Given this list of marker genes Mir129-2, Aste1, Lonp2, Uqcrc2, Asxl1, 4930451E10Rik, Kcnt2, Gpr107, Trbv30, Lum (lumican), Dnajc8, Tjp2, Slc25a38, Gm25856, Hvcn1, Anxa7 (NCBI Gene Id 11750), Recql, Uba52, Wfs1, Prickle4, Gm12333, Or5m5, Capza1, Zcchc14, Tm4sf5, Ugdh, Ccnt2, Fam241b, Nadk2, Gm42161, Lrrc4c, Vti1a, Pja1, Atp5mj, Trp53i13 (NCBI Gene Id 67875), Gm26176, Usb1, Gm12393, Nfkbiz, Zfp212, Gltpd2, Gm15039, Mir217, Heg1, Park7, Pold3, 1700020L13Rik, St3gal6, 8030423F21Rik, Lypd10, Sptb, Mpped2 (metallophosphoesterase domain containing 2), Il33, Arrdc3, Plin1, Pam, Uchl5, Atpaf1, Papola, Ecpas, Zfp599, 5730409E04Rik, Map6, Gm42918, Wdr12, Gm12401, Wipf1, Atg2a, Grip1, Mir568, Hoxa3, Nhlrc2, Nmi, Mir215, Ankib1, Jak1, Usp51, Ino80d, Cep63, Snhg14, Smpd1, Ces1d, Acad9, Ubxn1, Syne2, Cadm1, Gm26795, Thap1, Smad7, Znrf1, Chadl, Triap1, Cit, Taco1, 1500015A07Rik, Uqcrh-ps2, Cfh, Aspscr1, Fzd10os, Fbxo21, Plin2, Trp53cor1, 4933415A04Rik, Gm14175, BB218582, Tsg101, Tkt, Arl1, Pax2, Rian, Fam193b, Smagp, Otud4, Ralgps2, Pkd2l1, Gipc2, Rpl30-ps6, Vps72, Agtrap, Fry, Grm1, Tpd52, Ccdc9, Gm15780, Cers2, Zfat, Gtf2i, Rab43, Swsap1, Rpl10-ps2, Bcl2l13, Ephb6, Rassf1, Zfp975, Gm26490, Ckap2, Dnajc21, Rrp7a (ribosomal RNA processing 7 homolog A), Lsm10, Atxn1l, Smim8, Adal, Gm8969, Ebp, Cirbp, Zfp715, Anxa3, Xrcc4, Cklf, Alas1, Gm23706, Hhip, Ccdc74a, Src, Fbrsl1, E130114P18Rik, Plce1, Tagln2, Suv39h1, Gm13387, Ube2d2b, Gm5255, Heatr3, Dpep3, Zfp809 (zinc finger protein 809), Mir19a, Mfn1, Rapgefl1, Fbxl22, Sipa1, Fmnl3, Cdk2ap1, Pcmt1, Sntb2, Mrps10, Pms1, Gm15411, Mettl8, Rad50, Tnc, Drosha, Jup, Tmem42, Ppp1r15a, Rnf6, Gm23090, Zfp157, Opcml, Dhtkd1, Meis1, Niban3, Ric8b, Tmcc1, Altre, Synrg, Lancl1, Ehd4, Pomp, Tex14, Son, Smarcb1, Fmo1, Nrm, Rtel1, Pole3, Tbcd, Klk8, Mkln1, Larp4, 2310034O05Rik, Zfp36l1, Cyb5r1, Bmp5, Pde4dip, Rtl5, Lag3, Rgs16 (regulator of G-protein signaling 16), Dcbld2, 5730480H06Rik, Rrm2b, Dnajc11, Cep164, Or8g19, Slc36a1os, Kdm1a, Ly6g, Adgrl1, Mir5709, Atf7ip, Hint1, Mvd, A930001C03Rik, Gli2, Bnc1, Mms19, Prss43, Cltc, Slc4a1ap, Arf5, Maf, Mxd4, Gm13785, Gripap1, Mdm4-ps, Mfsd11, Or11a3-ps1, Gfer, Frat1, Phb1, Gm7285, Gadd45b, Pif1, Aurka, Fbxo28, 1700066B17Rik, Zfp438, Wdr75, Gm22270, Elp5, B4galt7, Gm12189, Mtus2, Pcmtd2, Treml4, Atf6, Pask, Gm25552, Gm25482, Gm13207, Rps6ka1 (ribosomal protein S6 kinase polypeptide 1), Nmnat2, Camk1g, Cpsf6, Map3k8, Vcan, Tpt1, Fanca, Gm10657, Rpsa-ps5, 2610206C17Rik, Rhot1 (ras homolog family member T1), Fam114a2, Ctdspl2, Git2, Zfp276, Zfp82, Uts2r, Paqr8, Ccndbp1, Ncapg2, Ptrh2, Snora81, Uimc1 (NCBI Gene Id 77298), Ager, App, 4930512H18Rik, Tet2, Gemin2, Zc3hc1, Rwdd4a, Celf1, Sirpd, Pccb, Phactr4, Sptbn2 (spectrin beta, non-erythrocytic 2), Gm10157, Gm22681, Dclre1a, Foxc1, Arpc5l, Itpa, Ccdc170 (coiled-coil domain containing 170), Eif4a2, Fgfr1, Ppip5k1, A830031A19Rik, Lgmn, Cystm1, Bcl11b, Maged1 (NCBI Gene Id 94275), Srsf11, Zfp790, Gm26871, Dhx38, Mir7035, Itga9, Gfm2, 2500004C02Rik, Npr3, Ncam2 (NCBI Gene Id 18257), Cbfb, Gm13110, Dot1l, Gm8213, Emc3, Bcas3, Kcnt1, Actr8, Or1e25, C330002G04Rik, Cldn22, Elavl4, Zbtb34, Adarb1, Gm25526, Rcan2, Myo18a, Ttll9, Atrx, Raf1, Tlcd3b, Hspa4, Tgif1, Sqor, Gm12125, Borcs5, Rps6ka3, Atp6v0d1, 1700003F12Rik, Nhlrc3, Gm25917, Gm16463, Gm26447, Hspd1 (NCBI Gene Id 15510), Garnl3, Glis3, Arhgef15, Gm11454, 2210417A02Rik, Prpf38b, Arhgef7, Sh3kbp1, Lifr, Hoxc11, Gins2, Tprg1l, Usp3, Gm19705 (predicted gene, 19705), Rbm25, Tbx3os1, Slc9a8, Zfx, 4930556N13Rik, Rtp3, Asic3, Gm15708, Arl3, Kdm5c, Scmh1, Plbd2, 4931406C07Rik, Slc8a1, BC043934, Dpp6, Tmem266, Gna11, Pi4ka, Skida1, Jph1, Arpp21, Zfp143, Ncoa4, Tomm34, Asb3, Isca1, Rere, Zbtb44, Nhsl2, Armh3, Serpine2, Ncaph, Ddb2, Tulp1, Diaph1, Crem, Spp1, Il1rapl2, Timm13, Sla, Mas1 (NCBI Gene Id 17171), Slc25a13, Appl1, Gm25224, Zcchc10, 4930533L02Rik, Map1lc3b, Gpr68, Btbd19, D630008O14Rik, Eif3k, Gpr45, 9330162B11Rik, Fam98c, Copg2, Adam32, AW047730, Aim2, Zfp319, Mrps31, Gm43772, Ppfibp2, Gm23182, 3110045C21Rik, C2cd4a, Tnfaip3, Pom121, Ube2f, Mirlet7g, Gigyf2, Pip4k2c, Emx2, Iho1, Smpd2 (NCBI Gene Id 20598), Gm4321, Acbd6, a, Xab2, Cox11, Nsun5, Ncor1, Ift140, Srebf1, Farsb, Hmgb1-rs16, Pde9a, Atrip, Gm26885, Gm11346, Gm22881, Wnk1, Gm10655, Tmem18, Apobec1, Ywhah, Cln3, Gm20033, Gm14098, Gm25608, Gm15651, Tmem134, Hnrnpu, Pdgfd, Gm17076, Catsper2, Chl1, 2310016D23Rik, Mgme1, Mta3, Magohb, Gm6462 (NCBI Gene Id 638892), Gm2990, Gm23769, Gm24068, Gm17815, Nr5a2, Plek, Rpl36-ps1, Plekhs1, Sspn, Sec23a, Usp1, Sulf1, Gm4832, Luc7l2, Gm20404, R3hdm2 (NCBI Gene Id 71750), Gm22935, Ipo11, Gm42799, Ankrd10, Ywhag, Gm12654, Cd164, Mepce, Onecut2, C1galt1, Ushbp1, Gm6985, Rpl6, Gm14125, Scd4, Sfmbt2, Gm4784, Dlk1, Ipo8, Pdlim1, Ccr4, Defb40, Gm23605, Gm12950, Lrriq1, Pde4c, Cpd, Slc43a1, Trpm1, Spice1, Bcas2, Gm11379, Ccdc63, Cd9, Mcm3ap, Gm15032, 1700120B22Rik, Rsu1, Phf24, Vav1, Csrnp3, Fuca1, Gm23502, Capn11, Cox7a1, Ifitm10, Tyw1, Cngb3, Gm12339, 2510002D24Rik, Zfp661, Mir376a, Rhoh, Best4-ps, Adra1a, Safb2 (NCBI Gene Id 433127), Pdcd6ip, Tfr2, Atp5f1a, Gm13689, Acvr1, Tanc2, Psmd7, 9530068E07Rik, Hdac4, Prkag1, Ifrd1, Txnl4b, Irf8, Edrf1 (erythroid differentiation regulatory factor 1), Ccdc185, Rsl24d1, Trap1, D830025C05Rik, Thoc2, Uba7, Ercc6, Gm7774, Nfat5 (NCBI Gene Id 54446), Agap3, Mob3a, Gm15047, Mir770, Cbr4, Psmd4, Mir7664, Actb, Pigb, Tmem248, Mir7673, Fgd4, Hormad2 (HORMA domain containing 2), Tspan8, Krtap20-2, Rnf169, Gm973, Acad11, Zdhhc6, Myo15a, Slc36a1 (NCBI Gene Id 76010), Gm12655, Slurp2 (secreted Ly6/Plaur domain containing 2), Cspp1, Hsd17b7, Fancd2, Zc3h12b, Taf1c, Rassf3, Sirt7, Pou2f1, Mir7668, Mindy3, Fbxl3, Hsf3, Ifng, Abca16, Snhg12, Nckap1, Ubqln4, Gm11691, Gm18254, Znfx1, Gckr, Notch4, Gm15927, Ubald1, Mir18, Rnf113a1, As3mt, Car7, Surf6, Mia2, Ttc13, Cfap69, Slc6a4, Gm23123, Mef2c, Syne4, Serpinb11 (serine (or cysteine) peptidase inhibitor, clade B (ovalbumin), member 11), Gm8883, Tfap4, Dennd2a, Arhgap27os1, Itpr2, Sfmbt1, Tmeff2, Ift81, Uba2, Rfc2, Sergef, Zmym1, 4930515G01Rik, Ascc1, Bcas1, A930018P22Rik, Gm23202, 1810053B23Rik, Rph3a (rabphilin 3A), Acbd4, Mto1, Gm29332, Hmgcr, Cdc42bpa, Mir6385, Fig4, Gm26247, Islr, Flt1, Limk2, Cyp2c70, Smim14, Shprh, Hoxa11os, Recql5, Mpi, 0610043K17Rik, 4930505A04Rik (RIKEN cDNA 4930505A04 gene), Srpk1, Fbxo11 (NCBI Gene Id 98072), Helz, Rps27a-ps3, Hs6st1 (NCBI Gene Id 50785), Prim2, B130024G19Rik, Rffl, Speg, Mindy1, Rell1, Hsd3b7, Gm23382, Nat10 (NCBI Gene Id 98956), Mrpl4, Map2k4, Taf6l, Cenpk, Med21 (NCBI Gene Id 97336), Atxn2, Gm8022, Efna3, Phactr1 (phosphatase and actin regulator 1, NCBI Gene Id 78746), Mid1, Tnfrsf1a, Rsph9, Neto1, 1700052H01Rik, Ufsp2, Gm13291, Stxbp3, Dnaaf9, Slc38a8, Tvp23b, Cygb, Plekha5, Smg5, Arhgap18, Pdia3, Spata6l, Setd7, Lrrc2, Arhgap12, Gm28401, Plekha6, Map4, Pgap2, Gm7891, Zfa-ps, Thoc2l, Abcb9, Gm11531, Taf4, Gtf2h2, Shc1, Synpo2l, Gm12501, Tor1aip1, Evl (NCBI Gene Id 14026), Tmem163, Clcn7, Arih2, Gm9887, Kcnk6, Map2k1 (mitogen-activated protein kinase kinase 1), Grin3b, Tmem131l, Ctnna3, Sun1, Gm15583, Ptprc, P2rx3, Magea2, Slc7a11, Mdfic2, Pipox, Thoc3, Dlgap5, Lbr, Rngtt, Mirg, Gm12610, Rfx7, Nrdc, Mir3092, Sertad2, Steap3, Rhod, Trim6, Nepn, Mir103-2, Rbm5, Lgals4, Vamp1, Lrig2, E2f2, 4930402F06Rik, Ube2e1, Tlr7, Palld, Ralgapa2, Gm5764, Pde4d, Atp7a, Gm13213, Zfp748, Tcp11 (t-complex protein 11), Lhfpl6, Ank, Caps2, Hsp90ab1, Uba5, Exosc1, Commd3, Stx3 (NCBI Gene Id 20908), Gmcl1, D030068K23Rik, Dbn1, Uvrag, Clec2e, Nudt1, Arl2bp, Baz1b, Stox2, Yipf1, Rex1bd, Matn3, Snph, Msh3, Plaa, Csde1, Gm15328 (predicted gene 15328), B3gnt7, Gm22422, Hbp1 (NCBI Gene Id 77235), Golga2, Mdc1, Platr6, B230208H11Rik, Il31, Abca4, Lztr1, Ilf2, Pnkp, Ddx23, Zfp507, Cenpi, Ephx3, Sass6, Klhl22, Tsga13, Gm16016, Gm22981, Tpk1, Acat1, Gm11802, Gm14534, Orc4, Gm16185, Tspyl2, Gm25102, Or6n1, Pgp, Hhat, Mir20a, Eif1ad, Gm10069, Acap1, S100a4, Mir7075 (microRNA 7075), G3bp2, Mgst3, Ddx60, Fbxl17, Tmem102, Nup160, Gm22122, Gstt2, Mycbp, Arhgap39 (Rho GTPase activating protein 39), Zp1, Hspe1, Gm13522, Rrp8, Gm6096, Rpl5, Cc2d2a, Gm4342, Gm11775, Snrnp25, Gm18901, Pkp4, Msrb3, Slc38a6, Tmco2, 2900079G21Rik, Gm10532, Dnttip2, Gdi2, Gm2800, Mcf2l, Rpl21, Hyls1, Milr1, Nme4, Gal3st1 (NCBI Gene Id 54452), Gm37885, Sp1, Lrp2bp, Ptp4a1, Uhrf1, Rbbp6, Zfp217, Elk4, Mecomos, B4galt6, Fam107b, Gm14082, Gm24592, Strada, Crot, Evc2, Fkbp8, 2410002F23Rik, Wdr43, Immp1l, Anapc15, Lyz1, Ccl7, Amz1, Cngb1, Psmd14, Gm27219, Gm22972, Gm26705, Echs1, Aknad1, Brix1, Ccdc116, Ngdn, Inpp5k, Bcar3, Neil3, Gm12653, Dis3l, Gm12271, Snta1, Cfap74, Gm27811, Brms1l, Slc25a19, Nrbp1, Slc12a6, Ruvbl1, Ints2, Ccdc110, Foxd2, Gata3, Nvl (NCBI Gene Id 67459), Ctnnal1, Bckdhb, Gm13180, Foxl2os, Sos2, Gm11655 (predicted gene 11655), Gm12828, Zfp946, Ptprr, Morf4l2, Elp1, Rbm47, Chd2, Parp14, Septin9, Cd164l2, Cse1l, Mb, Cplx4, Sec16a, Reps1, Mlxip, Tcp1, Gm12740, 1600010M07Rik, Ocrl, Zdhhc21, Rabl6, Aars1, Galnt1, Dlat, Hapstr1, Pik3cd, Fam83c, Eml6, Rpn2, Spcs1, Hnrnpr, Mgat1, Mrpl50, Ergic1 (endoplasmic reticulum-golgi intermediate compartment 1), Tmem161a, Kat14, Ppme1, Gm22973, Cryl1, Meox1 (mesenchyme homeobox 1), Eid2, Ogt, Wdfy3, Gm25848, Zfp318, Spin1, Vpreb1a, Nabp1, Atp8b4, Pole2, Best2, Nrbf2, Nmnat3 (nicotinamide nucleotide adenylyltransferase 3), Gm10531, Eif5al3-ps, Chrna10, Mettl4-ps1, Gm12980, Syt12, F830112A20Rik, Bag5, Fam169b, Klhdc2, Gm13842, Qtrt2, Rnaseh2a, Faiml, Crnde, Prss54, Spink10, Zfp532, Ak9, Papss2, Arf4, Gm5424, Gm12313, Ezh1, Gm9443, Adam17, Gulo, Gm43526, Cpsf1, Gm12091, Ankrd17, Mical2 (NCBI Gene Id 70877), Gm12109, Slc2a9, Zfp568, 1700023H06Rik (NCBI Gene Id 69442), Kcnip2, Nfe2, Tm2d2, A930019D19Rik, Dipk1b, Manba, Usp4, 9430007M09Rik, Zbtb8a, Rtl6, Zic1, Fxn, Mtfr1, Ccdc14, Eri3, Ift80, Slc25a51, Mgst2, Fhip2b, Serpinb10 (NCBI Gene Id 98753), Dohh, Oaz2-ps, Gm23483, C5ar2, Pak4, Nuak2, Erbb4, 2010016I18Rik, Tor1aip2, Hcfc1r1, Serpinb6e, Thbs3, Gm10073, Mast1, Rnf157, Slfn5, Setd2, Kcnh8, Luc7l3, Lrrc37, Gm25973, Rogdi, Parl, Pid1, Tango2, Tmed2, Gnpat, Hook3, Mir100hg, St14, Spred2, Runx1, Gm29707, Mir1191, Slc12a3, C2cd5, Pitpnc1, Itgbl1, Vps8, Cilk1, Rab3gap1, Pi4k2b, 5830487J09Rik, Rcc1, Pde4b, Mir19b-1, Flvcr1, Cdc42se2, 4930412F09Rik, Wdr5, Rasa4, Zpld1, Ttc33, Rtf2, Atg16l1, Gm26684, Btrc, Shmt1, Zfp27, Fxr2, Gm9134, Necap1, Bola2, Mir218-1, Dgcr8, Ndfip2, Setd1a, Gm26253, Samd10, Pou5f1, A530041M06Rik, Ndufa12-ps, Eva1c, Actc1, Hspa9, Sel1l3 (NCBI Gene Id 69691), Gm10309, Nr2c2, Hmg20b, Dkkl1, Map4k4 (NCBI Gene Id 98646), Sorcs2 (sortilin-related VPS10 domain containing receptor 2), Phf21a (PHD finger protein 21A), Snora17, Syt3, Rigi, Gm23054, Amhr2, Psma3, Tigd4, Nav2, Or2r2, Nr4a3 (nuclear receptor subfamily 4, group A, member 3), Fat2, 1110028F18Rik, A230083N12Rik, Izumo4 (NCBI Gene Id 71564), Tm9sf4, Msmo1, Synpo2, Capns1, Ech1, Arhgap15, Csdc2, Cyp4f15, Rnpep, Pigm, Ly6g6f, Rad54l, Hbq1b, Col10a1 (collagen, type X, alpha 1), Rcbtb1, 4930568G15Rik, Smpd5, Xpa, Snhg7os, Sned1, Gm12886, Dnah2, A2ml1, Ess2, Sardh, Smco4, Gm25091, Xpo4, Ighg1, Tmem33, Ece1, Mxd3, Cops8, Cntnap5c, Mfap1b, Taf1d, Gm11149, P2rx7, Selenon, Smg6 (NCBI Gene Id 216951), Septin12, Ube2d2a, Ebna1bp2, Spmip6, Eno4, 0610031O16Rik, Nfxl1, Alg11, Kcnj16, Ift122, Cep85, Gm12608, Cep44, Anp32e, Entpd1, Prkrip1 (Prkr interacting protein 1 (IL11 inducible)), Tbc1d14, Sbno1, 5830432E09Rik (NCBI Gene Id 67765), Mir7675, Slx4, Rassf9, Entpd8, Psma7, Pan3, Nipbl, Capn10, Syt8, Bcl6, A630072M18Rik, Adipor2, Vipr1, Ing3, Wsb1 (NCBI Gene Id 78889), Gm12571, Aff1, Fam76a, Rsbn1l, Ankrd40, Cp, Gm20443, Ext2, Tnks2, Fbxo31, Zbtb20, Tram1, Virma, Sez6, AI115009, Slc25a36, Rtn4, F2, Vgll4, Gm29994, Pdia4, Enah, Gm3830, Shroom3, Hexim2, Trim34a, Gm20005, Abo, Ttc39c, Foxp1, Gnl3, Lrrc8d (NCBI Gene Id 75118), Xpnpep1, Uqcrc1, Fra10ac1, Art1, Herc1 (NCBI Gene Id 78507), Gm6491, Fbxl20, Rgs9, Psph, Slc2a3, Ppp1r8 (NCBI Gene Id 230788), Rtraf, Ccdc47, Gpr157, Gm20706, Ribc2, Gm7831, G6pc3, Adam10, Tnik, Prkab1, Usp21, Tmem242, Arhgap28, Epdr1, Aen, Creb3l3, Fam90a1b, Tbc1d8b, Phf3, Rab11fip5, Babam2, Gm12848, Lhfpl2, Redic1, Zfp866, Slco1c1, Impdh1, Smc1b, Tlr2, Pierce2, Tcf4, Top3b, Gm15413, Plekhg1, Skic3, Snx1, H4c6, Tfrc, Gm11444, Togaram2, Vps39, Nrde2, Atp5f1b, Dpy19l1, Foxm1, Cars2, 9430015G10Rik, Tomm20, Shroom1, Gm16351, Eif3l, Gm24145, A830035A12Rik, Usp53, Cyp4a28-ps, Sapcd2, Glrx2, Mdk, D030056L22Rik, Gm28836, Taok2, Chchd10, AA986860, Rab34, St7, H2bw2, Gm24461, Mrpl21, Tbrg4, Pik3ap1, Sf3b1, Gm5532, Mir411, Gm25137, Lrrc23, Cul5, Gm24978 (predicted gene, 24978), Gjb3, Zc2hc1a, Faddos, Map2k3, Pitpnm2, Jakmip1, BC065397, Jade1, Ctsh, Rad51ap2 (NCBI Gene Id 633407), Psmc1, Nudt5, Kyat1, 2900092N22Rik, Rnf43, 1700017B05Rik, Acot11, Gm15197, Rad54l2, Oaz3, Trmt9b (NCBI Gene Id 319582), Crls1, Nell1, Abcg5, Rbm20, Fpgs, Hoxa11, Gm24780, Bex6, Gm11191, Rcor3, Mir6417, Mbtps2, Phf20, Gm4285, Gm15222, Gm8805, Agfg2, Abcf3, Clec4a1, Gm7181, Adcy7 (adenylate cyclase 7), Dse (NCBI Gene Id 212898), Sting1, Mir6381, Atp6v0a1, Fam162b, Cracr2b, Azin1, Six4, Nbdy, Mospd3, Gm5258, Pigx, Pfkfb1, Ncmap, Zfp512b, Tnfaip6, 1700036A12Rik, Gm24616, Adh1, Drg1, Gm14987, Mir3618, Slit2, Gm23479, Klf8, Fus, Klhl18, St6gal1, Sptan1, Aifm1, Vwa3b, Rp31-ps19, Xylb, Smc4, Pop1, Zbtb43, Cwh43, Gm12650, Gm16276, Mllt10, Mta2, Ppp2r5c, Alkbh1, Coq10b, St13, Cdh13, Tgoln1, Lingo4, Rptor, Rnf125, Asl, Dnmt3a, Mtmr3, Myh13, Plcxd2, Zfp612, Gm11665 (predicted gene 11665, NCBI Gene Id 100415912), Gm10244, Mroh7 (maestro heat-like repeat family member 7), Caap1 (caspase activity and apoptosis inhibitor 1), Fnbp4, Sycp2l, Ubap1, Gnai2, Ttyh2, Sf3a3, Bloodlinc, Ipo9, Mthfsd, Apom, Tns1, Mir99ahg, Tdrd9, Ppp1r10, Slc1a1, Kctd3, Mir3085, Ptp4a2, Ankdd1a, Tdrp, Fbxo42, Fzd10, Defb23, Satb1, Galnt3, Atp1b3, Spag5, Zfp653, Olig3 (NCBI Gene Id 94222), Mtf2, Nicn1, Cnga3, Phldb2, Gm6366, Paics, Mrm2, Il23a, Mettl13, En1, Kcnu1, Utp25, Tjp1, A530064N14Rik, Cd101, Stk36, Tpm3, Sybu, Hopxos, Klhl31, Clstn1, 4930526A20Rik, Oas2, 4933430I17Rik, Tac4, Shbg, Xpnpep3, Dync1h1, B630019A10Rik, Pex1, Ambra1, Nudt12, Pde7b, Hspa8, Mir654, Gm13347, Tmem45a, Gm28874, Ccdc198, Tmem200a, Gm26044, Gm12936 (NCBI Gene Id 675326), Nasp (nuclear autoantigenic sperm protein (histone-binding)), Atcay, Ttc3, Gaa, Ralbp1 (NCBI Gene Id 268968), Dph2, Stk11ip, Gm5619, Metap2, Sec24c, Yipf6, Usf2, Snora61, Setdb2, Gm12977, Setx, Nabp2, Gm7928, Bmt2, Fgd5, Ube2z, Mir1306, Mrpl22, Raver2, Aip, Mir763, Defb42, Trip12, 4933408N05Rik, Pgpep1l (pyroglutamyl-peptidase I-like), Adamts6, Nrgn, Rpl21-ps9, Or4c35, Phex, Igf1r, Pcdhga8, Gm20544, Gm15066, Kcnv2, Gm4877, Mdn1, Strap, Gm11452, Gm5976, Vps4a, Ppp4r4, Ino80dos, Gm14111, Mrpl28 (NCBI Gene Id 68611), Acaa1b, Crcp, 1700094J05Rik, Phyh, Ttc29, Tle3, Gm19224, Mir17hg (NCBI Gene Id 75957), Gm24793, Med18, Rbpms2, Gm25184, Atp8b3, Gfm1 (G elongation factor, mitochondrial 1), Kdm5a, Misp, Cyb5r3, Inpp5b, Gm13755, Ube2r2, 2310009B15Rik, Cdkn1a, Gm5248, Rps2-ps11, Gm25609, Or10ad1, Rsrc1, AU016765, Rufy2, Arl6ip5, Ipo13, Atp5f1d, Slc25a14, Mat2b, Mir7238, Gamt, Gm16089, Atp6v0b, Mroh1, Gins1, Gm14101, Thoc1, Gm5787, Stra6 (stimulated by retinoic acid gene 6), Zfp7, Tceanc2, Gm24878, Kash5, Gm16599, Nrl, Eef2k, Pstpip1, Gm30835, D830032E09Rik, Bltp2, Gm6209, Radx, Uts2, Mecom, Gm7094, Lat2, 4933434E20Rik, Gm2245, Pknox1, Ganc, Fam83e, Smg7, Mir376c, Shisa5, Mzf1, Lyg1, Mir3099, Rai1, Lyzl6 (lysozyme-like 6), Sinhcaf, Mgat5, Gzmm, Marchf2, Gm10268, Nop58, S1pr4, Fancl, Zmiz2, Nemp2, Tra2b, Gm31266, Eps15, C530043K16Rik, Magi2, Casp8, Ankrd1, Ms4a4c, Ptges3, Pigc, Pik3ip1, Kif22, Lrrc75aos1, Nectin3, 4932412D23Rik, 4930509H03Rik, Snora16a, Ica1l, Plekhm3, Lamp2, Lratd1, Ccdc88a, Tmem219, Zfand4, Gm16283, Pcdhgc5, Tenm4, Mir376b, Aldoa, Naprt, Srsf1, Yeats2, Mir7669, Esr2, Gm25968, Babam1, Tmcc2, Mylpf, Mir17, Adgrb3, Mir6944, Gm15881, Fnta, 2010109A12Rik, Uggt1, Trpv2, Pkdcc, 1700001O22Rik, Poc1a, Lst1, Phip, Ubtd2, Pigh, Runx2, Slc41a2, Slc3a2, Nkain1 (NCBI Gene Id 72746), Man2c1, Dhx33, Rpl9-ps4 (NCBI Gene Id 100042832), Txndc2, Arhgap23, Tpd52l2, Rragc, Pou6f1, Brd1, Snora44, Slc7a7, 1810044D09Rik, Tbx15, Gm14227, Uevld (NCBI Gene Id 71499), Slc27a5, Snf8, Ninj2, Abcc3, Spmip3, Morc4, Spats1, Slc35a3, Kctd5, A430005L14Rik, Pspn, Gm25788, Desi1, Zfp280d, Gm26049, Rhbdd2, Gm15610, Or4k52, Cldn12, Mir3475, Platr22, Dars2, Arhgap4, 5031434O11Rik, Lypd6b, Syngap1, Irf3, Ankrd60, Gm9506, C030013C21Rik, Plcl2, Slc18a3, Gm28729 (NCBI Gene Id 102635744), Zhx3, 9230104M06Rik, Nrg4, Camk1, Zpbp2, E2f1, Esrp1, Fgf9, Zwilch, H2-M5, Fkbp4, Echdc2, Erg, Selplg, Adat1, Gm26070, Gm24665, Ankrd24, Ubap2l, Rab27a, Gm12924, Dhx9, Fau-ps2, Cnbd2, Gpr35, Eva1b, Gm11827, Ube4bos3, Prrc2c, Gcnt7, Arfgef1, Ctbp2, Myom3, Crb2, Sos1, Siglecg, Pax6, Srrm1, Gm43522, Rad1 (RAD1 checkpoint DNA exonuclease), Lrrc42, Cct3, Il2ra, Egr3, Top2a, Gpr84, Scn9a, Lbhd1, 1700039M15Rik, Fam171b, Slc22a7, Cars1, Idh3b, Tjp3 (tight junction protein 3), Erc1, Ccdc191, Cacna1c (NCBI Gene Id 619317), Zbtb8b, Tnfrsf26 (NCBI Gene Id 244237), Ep400, Pla2g6, Sema4g, Sema4d (sema domain, immunoglobulin domain (Ig), transmembrane domain (TM) and short cytoplasmic domain, (semaphorin) 4D), Socs2, Ubap2, Nostrin, Hook1, Irf5, Itih3, Arhgap26, Fbxo8, Rtl1, Plpp6, Ttf1, 1700022A21Rik, Ccdc162, Mrpl9, Ppp4r1, Mir541, Mcph1, Rpl14-ps1, Hkdc1, Tatdn2, Hsd17b14, Ddx20, Sqstm1, Usp10, Psmd11, Fosl2, Stk31, 9330175E14Rik, Otx2, Cttnbp2, Morf4l1, Fhl1, 1700052I22Rik, Eif3d, Vmn1r228, Snora2b, Klf1, Lhfpl4, Prr23a1, Tpr, Lrch2, Pde8a, Zfp747l1, Spock2, Mir194-1, Myo3a, Gnas, Matr3, Akr7a5, Mamstr, Mmp19, Ece2, Gc, Tifab, Pigg, Kmt2d, Nkapl, Pdpr, Meg3, Zcchc7, Gm23347, Ubr7, Pick1, Mstn, Ptcd2, Gm30292, Gm15895, Lce3c, Gm13662, Calcoco2, Shf, Ercc6l, Gm24888, Nupr1, Oser1, Tmem61, Arl14ep, Phox2b, Mfge8, Pnpla7, Phlpp2, C230071H17Rik, Tldc2, Tank, Cerkl, Epb41l4a, Pzp, Fyb1, Ptpn11, Ets1, Carhsp1, Eif2d, Jph4, Pex11a, Ltbp3, Ercc2 (excision repair cross-complementing rodent repair deficiency, complementation group 2), Gm12101, Gm4961, Morrbid, Usp49, Otx2os1, Gm11197 (NCBI Gene Id 108167859), P4ha2, Gpc1 (NCBI Gene Id 98368), Agpat2, Pomgnt1, 1700101I11Rik, Galnt17, Patj, Gpr85, Sox15, Acyp1, Gm14218, Dnajc13, Alyref (NCBI Gene Id 21681), Gm29243, Ldha, Tamm41, Vac14, Zmynd12, St6galnac2, Or2c1, Homer1, Terf2, 4930532M18Rik, Fmc1, Snhg17, Gm12803, Rbm6, Vwc2l, Defb47, Gm26205, Stat3, Mttp, here is a description of the gene set: from publication Yevshin I, Sharipov R, Kolmykov S, Kondrakhin Y, Kolpakov F (PMID 30445619) Mouse Gene Set: ZFP874B_TARGET_GENES studied in species Mus musculus